The following is a description of a gene set: part of: Phase II - Conjugation of compounds studied in species Mus musculus electronically inferred by orthology from the curated human pathway This event has been computationally inferred from an event that has been demonstrated in another species.<p>The inference is based on the homology mapping from PANTHER. Briefly, reactions for which all involved PhysicalEntities (in input, output and catalyst) have a mapped orthologue/paralogue (for complexes at least 75% of components must have a mapping) are inferred to the other species. Reactome Pathway: Cytosolic sulfonation of small molecules, and this is the list of marker genes: Bpnt1, Sult1c2, Sult6b1, Podxl2, Sult1b1